Given this list of marker genes Psma6, H2ac11 (H2A clustered histone 11), H2ac24, Psmd7, Hcfc1, Psmc6, Psmc2, Psma4, H2ac19, H2ac4, Foxk1, Psmc4 (NCBI Gene Id 23996), Psmd1, H2ac1, H2ac15, Ino80b, H2ac13, H2ac6, H2ac25, Psmb7, Ubb, Psmc5, H2ac12, Psmb5, Psmd13, Psma7, Bard1, Psma3, H2ac7, Psma1, Ino80c, Rps27a, Yy1, H2ac8, Psmd6, Psmc1, Asxl1, H2ac22, Psma2, H2ac20, H2ac10, Nfrkb, Nedd8, Psma5, Psmd12, Tfpt (NCBI Gene Id 69714), Uchl3, Psmb4, Kdm1b, Psmc3, Psmb6, Asxl2, H2ac23, Senp8 (SUMO peptidase family member, NEDD8 specific), here is a description of the gene set: part of: Deubiquitination Reactome Pathway: UCH proteinases species: Mus musculus This event has been computationally inferred from an event that has been demonstrated in another species.<p>The inference is based on the homology mapping from PANTHER. Briefly, reactions for which all involved PhysicalEntities (in input, output and catalyst) have a mapped orthologue/paralogue (for complexes at least 75% of components must have a mapping) are inferred to the other species. electronically inferred by orthology from the curated human pathway